The following is a description of a gene set: Human Gene Set: GSE17974_IL4_AND_ANTI_IL12_VS_UNTREATED_1H_ACT_CD4_TCELL_UP from publication Elo LL, Järvenpää H, Tuomela S, Raghav S, Ahlfors H, Laurila K, Gupta B, Lund RJ, Tahvanainen J, Hawkins RD, Oresic M, Lähdesmäki H, Rasool O, Rao KV, Aittokallio T, Lahesmaa R (PMID 20620947) Genes up-regulated in comparison of CD4 T cells treated with IL4 and anti-IL12 at 1 h versus the untreated cells at 1 h. The aim of this dataset was to study in detail the transcription kinetics initiated by cytokine IL-4 in early differentiation of Th2 cells. studied in species Homo sapiens, and this is the list of marker genes: NUTM2B, SLC6A20, PDE4B, MRPL35, PPP1R14A, SGCE, LINC01550, TEKT3, MSLN, PAX5, GAST, PLXDC1, CEP89, ROS1, LINC02609 (long intergenic non-protein coding RNA 2609), CHST4, CCL26, TAGAP, TMEM214, SYCE2, CD163, PTGIR, CLRN1, MBD3L1, SLC11A2, C8orf74, ARL2BP, HDDC3, FAM167B, JRKL, LCE2B, RGS16, NFIL3, GPR18, MID1, MIR21, KCNK2, PCP4L1, HEATR4, SPAM1, SLC24A2, ENSG00000223438, GOSR2, PIPOX, IRAK4, LRRN3, CTSA, APPL2, IRGM, GPR143, MAPK8IP3, TMEM168, CDC42EP5, TMEM212, ATG16L2, SPATA31E1, POTED, ZSCAN31 (zinc finger and SCAN domain containing 31, NCBI Gene Id 91921), MAP4K3-DT, CLCN2, GJB2, TTC9C, UNC13A, MKRN3, ALCAM, NFKBIZ, DUOXA1, LINC00921, TRIM38, IFT81, CD274, NKD1, PRAC1, GRAMD1C, OR5H1, TLX1 (NCBI Gene Id 3195), KCNQ1DN, PIWIL2, DACT1, TAL1, FARP1, LINC00115, TMEM200C, CASP3, COBL, FRZB, TMEM277P, GCSAM, GREM2, LACRT, TLR1, DCAF10, ZNF443, TARBP1, CNTNAP3B, LIN9, H2BC21, PCDHB1, DAO, TBC1D22A-AS1, GAPDHP62, TAC4, SOCS1, LINC00636, NETO1, KLC4, CAGE1, ADAM32, GATA3, RTP4, A1BG-AS1 (NCBI Gene Id 503538), NTRK1, FREM1, CD200R1, MAMDC4, BHLHE40, CC2D1B, CISH, CES4A, CELP, TMEM196, MAP2K7, PWWP3B, OXER1, EPM2AIP1, TYW5, AXIN2, YPEL1, SV2A, ID2, PRDM14, TARP, ADCK1, C5AR2, ENSG00000275427, ELOVL3, LUZP2, SORCS2, TTYH3, GORASP1, TMPRSS11E, GPR183, ADHFE1, TRIB2, ZNF563, GGT7, KRT222, CDKL5, LINC02297, EVI2B, PTPRR, ALOX12, TBX15, FAM118B, SLC66A1LP, IL2RA, RASL10B, SCART1, MOB3A, MEGF11, SYBU, LINC00852 (NCBI Gene Id 84657), APC2, RELCH, SOCS3, IL9R, PTH2, S1PR1 (sphingosine-1-phosphate receptor 1), ADAMTS8, GCSIR, TUG1, H2AC17, BRF1, ZNRD2-DT, CFAP52, TSC22D4, TMEM53, TPST1, TCP11, SOX11, PGAP1, MTUS2-AS1 (NCBI Gene Id 731614), NPHP4, PCED1B, KLK13, AMIGO2